Given this list of marker genes GPC1, SGSH, GYG2, ADAMTS2, TALDO1, MCCC2, THSD7B, SBSPON, B3GAT3, CBLIF, SLC37A4, TCN2 (transcobalamin 2), HIBCH, GALT, CYP11A1, GPC2 (NCBI Gene Id 2818), NEU1, AUH, BCKDHB, PNP, ADAMTS8, MUCL1, ACAT1, SRD5A3, ALG12, AGRN, ADAMTS16, MMAB, GALE, RPS27A, ACY1, ADAMTS19, BCKDK, MMACHC, UGT1A1, DLD, CYP26B1, CYP21A2, NCAN, ABCD4, GYS2, MC2R, AHCY (adenosylhomocysteinase), B4GALT7, GSS, BCAN, THSD1, SLC34A2, CSPG5, GYS1, SDC2, EPM2A, MUC20, BCKDHA, SDC1, PPP1R3C, GPC5, GPC6, MTR, PCCB, MGAT2, MAT1A, GNE, DOLK, NAGLU, CSPG4, ADAMTS13, NOTCH4, OGN, CTSA, ALG14, B4GAT1, ADAMTS1, ST3GAL3, GALNT3, FDXR, CHSY1, MMUT, ADAMTS12, IVD, MUC5AC, HGSNAT, PGM1, MAN1B1, LUM, VCAN, MMADHC (NCBI Gene Id 27249), B4GALT1, ALG8, ADAMTS4, AMN, IDS, UGT1A4, ADAMTS15, MUC16, OPLAH, GPC3, CYP27A1, CHST3, UBB (ubiquitin B), DCN (NCBI Gene Id 1634), ADAMTS9, MMAA, POMT1, SPON2, FMOD, GALNT12, ADAMTSL1, GALNS (galactosamine (N-acetyl)-6-sulfatase), ADAMTS7, ADAMTS20, LARGE1, MOGS, MCCC1, GALK1, POMT2, IDH1, GFPT1, NHLRC1, PAH, MUC15, KERA, C1GALT1C1, ADA (NCBI Gene Id 100), PMM2, CHST6, ARSB, NOTCH3, CYP27B1, ALG11, ADAMTS17, SFTPC, PCCA, RFT1, OMD, SFTA3, EXT2, B3GALT6, SFTPB, MUC1, RPIA, SDC4, ALG3, ALG1, CYP11B2, CYP2U1, ADAMTS14, MPDU1, UBC, APRT, BTD, LCT, ADAMTS3, SDC3, IDUA (alpha-L-iduronidase), MTRR, SEMA5A, THBS2, MUC6, ALG2, GYG1, ADAMTSL4, ALG6, NUS1, DAG1, ACACA, B3GLCT, DHDDS, DCXR, ADAMTS5, GCLC, THSD7A, GUSB, DPAGT1, THBS1, UBA52, MPI, ADAMTS18, CYP2R1, LFNG, TPMT, ACAN, MUC5B, GBE1, SEMA5B, MUC13, GPC4, DPM1, DPM2, SI, HSPG2, G6PC3, ALG9, LMBRD1, DPM3, PPM1K, CYP11B1, HPRT1, SFTPA2, FDX2, DBT, MUC17 (mucin 17, cell surface associated), GAA, CFP, GCLM, CSF2RA, C1GALT1 (core 1 synthase, glycoprotein-N-acetylgalactosamine 3-beta-galactosyltransferase 1), ADAMTS10, GNS, MUC7, MUC3A, KHK, SPON1, HEXB, GLB1 (galactosidase beta 1), MUC4, THSD4, CYP24A1, POMC, MUC21, CYP17A1, HLCS, HEXA, EXT1, ABCA3, CYP7B1, ALG13 (NCBI Gene Id 79868), GALM (galactose mutarotase), SLC35D1, FDX1, ECHS1, ADAMTS6, PC, TBXAS1, G6PC1, ADAMTSL5, ADAMTSL2, NOTCH1, MAOA, HYAL1 (NCBI Gene Id 3373), GGT1, CHST14, CYP19A1, CYP4F22, FMO3, MUC12, CSF2RB, PRELP, BGN, ADAMTSL3 (NCBI Gene Id 57188), CYP26C1, SLC26A2, ALDOB, SFTPD, CD320, NOTCH2, CUBN, PAPSS2, SFTPA1, POMGNT1, CYP1B1, SSPOP, here is a description of the gene set: Diseases of metabolism Human Gene Set: REACTOME_DISEASES_OF_METABOLISM species: Homo sapiens